The following is a description of a gene set: studied in species Mus musculus Reactome Pathway: Cooperation of PDCL (PhLP1) and TRiC/CCT in G-protein beta folding This event has been computationally inferred from an event that has been demonstrated in another species.<p>The inference is based on the homology mapping from PANTHER. Briefly, reactions for which all involved PhysicalEntities (in input, output and catalyst) have a mapped orthologue/paralogue (for complexes at least 75% of components must have a mapping) are inferred to the other species. part of: Chaperonin-mediated protein folding electronically inferred by orthology from the curated human pathway, and this is the list of marker genes: Gna14, Cct5, Cct6b, Gnb3, Cct2, Rgs9, Gng10, Cct6a, Gng11, Gng4, Gnb2, Rgs6, Gngt2, Gng8, Cct3 (chaperonin containing TCP1 subunit 3), Gng3, Gnb5, Rgs7, Gngt1, Csnk2b, Cct7, Gng5, Gng7, Cct8